The following is a description of a gene set: Genes predicted to be targets of miRBase v22 microRNA mmu_miR_1b_3p in miRDB v6.0 with MirTarget v4 prediction scores > 80 (high confidence targets). from publication Chen Y, Wang X (PMID 31504780) Mouse Gene Set: MIR_1B_3P studied in species Mus musculus, and this is the list of marker genes: Pcdhgb2, Pcdhga8, Chd8, Tpgs2, Irf4, Pgpep1, Adora2b, Nav1 (neuron navigator 1), Pcdhga12, Elmo1, Suox, Pcdhgc3, Zfp112, Pcdhga7, Tent5c, Ppm1f, Txlna, Xrcc4, Elovl2, Aldh3a2, Pcdhgc4, Igf2, Pcdhga9, Mettl25b, Zmym3, Sft2d3, Zmym2, Cyrib (CYFIP related Rac1 interactor B), Col8a1, Nsd3, Pcdhga6, Pcdhgb5, Gbp10, Ubr5, Pcdhgc5, Inmt, Map3k10, Pcdhga4, Atf7, Gbp6, Pcdhga10, Gdpd5, Pcdhga11, Tspan3, Pcdhga2, Gm38666, Pcdhga3, Phf3, Pcdha4b, Tal1, Snrpa, Slc2a13, Ppp1r3a, Naip1, Zfp950, Fam149b, Pcdhgb8, Uvrag, Chl1, Mmab, Pcdhga5, Klrd1, Tmem121, Slc7a8, Rbpms2, Pcdhgb4, Macrod2, Pcdhga1, Pcdhgb7, Hsd17b13, Zfp940, Guf1, Pcdhgb6, Cftr, Keap1, Scoc (short coiled-coil protein), Zc3hav1, Peg10, Pcdhgb1, Tesk2